Given this list of marker genes DGCR8, SEPTIN9, SMAGP, MAGEA4, SLC6A12, TDRKH, SYNE2, AKR1C1, ARHGAP45, CAPN3, CUX1, DMXL2, DCLK1, BBS9, EXOC1, CIRBP, SLC46A3, PCSK7, CBX7, BRD3, ZNF665, SLC10A2, KLF4, HS3ST1, SCYL3, MPHOSPH9, KAT6B, ZNF202, PEX16, KLRB1, CAPN9, TRIM44, PBXIP1, GLTP, ZNF211, INPP4B, AKAP9, CYP3A43, PAX1, CAPRIN2, PDCD4-AS1, RALGPS1, SLC22A18, ZNF337, TRIM33, DBP, TRAPPC2, SIK3, RYK, MAPK1 (NCBI Gene Id 5594), FGF22, PCDHB13, SLC26A3, PCF11, C14orf93, RPL39 (ribosomal protein L39), CBR4, AK1, LY9, CASP1, JMJD1C, HLA-C, IGFBP6, CCR6, RPL30 (NCBI Gene Id 6156), CRTAP, HNRNPA3, NR3C2, RIC3, TCF7, SMIM7, MACF1, KRTAP1-3, MED14OS, S100PBP, CCNL1, IL18, USP25, ESM1, RAP1GAP2, HLA-B, DGKD, GOLGA8A, RIPOR2, PLEKHA1, FKBP11, CXCL6, RPL6, EDN3, PRAF2, ABCC4, RENBP, FOXJ3, KLRF1, ADA2, MAPKAPK5-AS1, MAP3K3, RASA1, IL11RA, ALG13, ADGRL1, CTDSP2, CARS2, LRRC37A2, FOXO3, BIN1, TNFRSF14, PLEKHG3, CD44, PLSCR3, TASOR, MARCHF8, LZTFL1, MMP15, RSBN1, CLSTN1, SON, CRBN, HSPBAP1, USP46, MAN2A1, IL10RA, CA5B, TNXB, NR3C1, MVB12B, CTSS, TSC22D3, TMEM168, TGIF1, PARP6, AKT3, ZFP36L2, PHF1, ZNF813, RUFY1, SLC6A16, IRS2, N4BP2L2, TBC1D8B (TBC1 domain family member 8B), STK10, CEP350, EPM2AIP1, LY75 (NCBI Gene Id 4065), TULP4, ITGA5, DAZAP2, TRMO, CAMTA1, PHC1, PLAC8, AHCYL2, CTSO, CD6 (NCBI Gene Id 923), ICAM2, DCAF8, RALGAPB, BLTP1, PGAP3, NADSYN1, HNRNPA1, AGL, ZNF184, RAB11FIP4, HSD17B8, ZNF137P, SEC31B, GATA3, SETD2, TNKS, CD52 (CD52 molecule), ADARB1, RUNX1 (NCBI Gene Id 861), FCMR, RADX (RPA1 related single stranded DNA binding protein, X-linked), RHO, DIP2C, ZNF506, LSM14A, GPR183, CYP2E1, RESF1 (NCBI Gene Id 55196), ATP2C2, PARM1, TRIM13, GUCA2A, TXNIP, ZNF32, PNLIPRP1, CPQ, ABCC5, TSC1, EIF4A2, CCNT2, PRKACB, RPS17P5, HERC1, here is a description of the gene set: from publication Jeffrey KL, Brummer T, Rolph MS, Liu SM, Callejas NA, Grumont RJ, Gillieron C, Mackay F, Grey S, Camps M, Rommel C, Gerondakis SD, Mackay CR (PMID 16474395) species: Homo sapiens Genes up-regulated in comparison of memory CD4 T cells versus Th1 cells. In the present study we used Affymetrix oligonucleotide microarrays to produce gene transcription profiles for the major leukocyte types in humans. This comprehensive dataset enabled us to not only establish which genes were expressed in each leukocyte type, but also which genes were expressed in each subset after activation. The used of a comprehensive dataset of gene profiles from all the major human leukocyte subsets enabled a novel and powerful means for identification of genes associated with single leukocyte subsets, or different immune paradigms. Human Gene Set: GSE3982_MEMORY_CD4_TCELL_VS_TH1_UP